Given this list of marker genes Ptprh, Ptpro, Ptprt, Synj2, Nron, Plek, Bmp2, Acp3, Ppp3r1, Hpn, Inpp5b, Cdk5rap3, Dusp1, Sgpp1, Ppp2r3d, Ptpn3, Btrc, Dusp13b, Dusp6, Rock1, Ptprk, Dusp11, Eya3, Dusp12, Eya2, Sdhaf2, Dusp2, Pdxp, Stk11, Dusp10, Dusp15, Ppp1cb, Inpp5a, Ppm1a, Ppp6c, Dusp22, Tns2, Inpp5e, Ppp2r1a, Plppr4, Gpld1, Plpp6, Ccdc159, Ptpn5, Synj1, Ppp1cc (NCBI Gene Id 627816), Fam220a, Ptpn12, Ppp1r42, Ctdnep1, Thtpa, Pip4p2, Dusp29, Mtmr1, Ppp1ca, Fbp1, Ssh1, Inpp5k, Pten, Pdp1, Ssh2, Ptpn2, Src, Mtmr7, Dusp5, Dusp8, Mtmr6 (myotubularin related protein 6, NCBI Gene Id 219135), Il3, Ppp2r2a, Ptprb, Ppp3cc, Ptprr, Plpp3, Eya1, Chp2, Tmem225, Mtmr2, Ppp2r3c, Ppp5c, Plpp4, Ptprm, Igbp1b, Ppp3ca, Ptprj, Chp1 (NCBI Gene Id 80510), Uri1, Mtmr12, Ppp1r15a, Acp4, Dusp18, Ptprz1, Ripk3, Ptpn11, Ppm1m, Bcl2, Adora1, Chrm5, Dusp26, Plppr3, Ephx2, Plppr5, Ppp3cb, Ptprf, Fig4, Ppp1r17, Dusp3, Akp3, Pip4p1, Ptpn7, Sacm1l, Npnt, Bag4, Inpp5j, Ptpn13, Dusp21, Dusp4, Mef2c, Pptc7, Ppm1e, Cttnbp2nl, Ppp4r3b, Inpp5d, Nt5c, Ppp1r12a, Ptpn9, Mtm1, Acp5, Ptprc, Dusp19, Ocrl, Timm50, Epm2a, Ptpru, Dusp7, Ppm1b, Ppp2r5d, Tnf, Ppp2r5a, Nceh1, Sgpp2, Ptpn1, Ptprs, Mtmr4, Ptpn22, Ppm1j, Ppargc1b, Ppm1d, Inpp4b, Ppp4r3a, Plppr1, Mtmr3, Igbp1, Ppp2ca, Ifng, Ctdsp1, Fbxw11, Tmem132c, Ppm1g, Ptpn6, Pgam5, Plpp1, Plppr2, Dusp16, Phpt1, Ctdp1, Ubash3b (ubiquitin associated and SH3 domain containing, B), Inppl1, Mtmr10, Inpp5f, Smg5, Cdc14b, Dusp23, Plpp5, Ctdspl2, Ppm1f, Drd2, Mtmr11, Iqgap1, Thnsl2, Mtmr9, Plpp2, Ctdsp2, Dusp28, here is a description of the gene set: species: Mus musculus The process of removing one or more phosphoric (ester or anhydride) residues from a molecule. Mouse Gene Set: GOBP_DEPHOSPHORYLATION